Given this list of marker genes Uox, Upb1, Mgat1, Dera, Gda, Urah, Nudt1, Cda, Cdadc1, Dctd, Adal, Ahcyl, Aicda, Galt, Pnp, Xdh, Upp1, Pnp2, Enpp4, Entpd4 (ectonucleoside triphosphate diphosphohydrolase 4), Entpd7, Ahcy, Entpd4b, Dpyd, Upp2, Ada, Pycr3, Urad, here is a description of the gene set: studied in species Mus musculus Mouse Gene Set: GOBP_NUCLEOBASE_CONTAINING_SMALL_MOLECULE_CATABOLIC_PROCESS The chemical reactions and pathways resulting in the breakdown of a nucleobase-containing small molecule: a nucleobase, a nucleoside, or a nucleotide.